Given this list of marker genes SVIL, TSHB, NRK, EFNA1, MFAP2, BATF3, HSPA4L, PLA2G2C, SSTR4, SLC10A6, SMYD1, P3H4 (NCBI Gene Id 10609), ZNF740, TGFBI, PDE1A, OR13J1, INTS14, BCAS3, CEBPD, PIP, TWIST2, MYBL2, RGS14, IRF6, CEACAM21, AKAP12, LSP1, CTF1, FXYD1, IL6, DNAJC10, GFRA3, PHAF1, TNFSF8, KIF1B, PHF13, SMIM1, POU2F3, DMTF1, NNAT, MT4, PSMD9, INS, PLCG1, RPL22, MRC2, EPS15L1, CACNA2D1, TBX3, KRT27, CDC20, PFDN5, DAPK2, NAA60, FGR, PIM3, LTBP4, HOXD13, ZIC4, TPH1, SGO1, MAG, CANX, TINAGL1, DGKA, SSR1, DHH, ARID3A, FOXA2, CYP27B1, CDON, GYG1, GPN1, CRYBG1, CPNE3, C5, CCL19 (NCBI Gene Id 6363), LTC4S, LDB1, RPS14 (ribosomal protein S14), MSX2, PDGFRA, OSBPL1A, CCT2, IGHM, PAX5, PSPN, CALML5, AZI2, SRCAP (NCBI Gene Id 10847), MPL, SEC11C, GOLIM4, CEL, VCAN, PKIA, ELAVL4, RHAG, GRK5, PCNP, IGLC1, JOSD2, RGS7, HNF1B, APRT, KCNH2, CDCA5, GAS6, FIGNL1, CYP3A7, MLLT11, KLF5, S1PR1, CYP24A1, HSD11B1, SEMA4B, BAIAP2L1, CCR1, KCNJ15, DPEP1, RXYLT1, ARHGAP39, SLC38A4, FOXG1, BTG4, KRT8, GATM, PCDHA11, ANAPC1, GAL, PLBD1, CDK8, SAR1A, OGG1, FBXL5, HNF4A, COQ5, MEP1A, CACNA1B, TPPP3, GDPD3, VHL, STMN2, CIDEB, STRA6, PDLIM4, MAP2K2, DNA2, NTSR1, GPX1, ZMIZ2, INSM1, CD22, GLTP, FBP1, PLAC1, EPB41L4B, CCNF, RARG, HHEX, TENM1, CNTNAP1, MRPL55, HRAS, SERPINB2, CST9L, FAM111A, FBN1, ELF3, POU3F4, CHEK2, CTNNBIP1, SOAT2, SCN3A, RHOD, SNX9, RMND5A, CCKBR, PNKD, MYB, CNGA3, TRPC5, ASXL1, HPS1, ZNF277, ELMOD3, PGRMC2, MYO1D, HTRA3, VPS26B, SLC9A1, ZNF799, RPL5, CLDN2, HSD17B1, BAAT (NCBI Gene Id 570), FJX1, SMARCA2, DCUN1D2, KRT86, here is a description of the gene set: Despite their enormous importance, the molecular circuits that control the differentiation of Th17 cells remain largely unknown. Recent studies have reconstructed regulatory networks in mammalian cells, but have focused on short-term responses and relied on perturbation approaches that cannot be applied to primary T cells. Here, we develop a systematic strategy – combining transcriptional profiling at high temporal resolution, novel computational algorithms, and innovative nanowire-based tools for performing gene perturbations in primary T cells – to derive and experimentally validate a temporal model of the dynamic regulatory network that controls Th17 differentiation. The network is arranged into two self-reinforcing and mutually antagonistic modules that either suppress or promote Th17 differentiation. The two modules contain 12 novel regulators with no previous implication in Th17 differentiation, which may be essential to maintain the appropriate balance of Th17 and other CD4+ T cell subsets. Overall, our study identifies and validates 39 regulatory factors that are embedded within a comprehensive temporal network and identifies novel drug targets and organizational principles for the differentiation of Th17 cells. Human Gene Set: GSE43955_1H_VS_42H_ACT_CD4_TCELL_DN species: Homo sapiens from publication Yosef N, Shalek AK, Gaublomme JT, Jin H, Lee Y, Awasthi A, Wu C, Karwacz K, Xiao S, Jorgolli M, Gennert D, Satija R, Shakya A, Lu DY, Trombetta JJ, Pillai MR, Ratcliffe PJ, Coleman ML, Bix M, Tantin D, Park H, Kuchroo VK, Regev A (PMID 23467089) Genes down-regulated in CD4 T helper cells Th0: 1h versus 42h.